Given this list of marker genes Cdc27, Sox9, Pdia4, Zfp422, Igf1r, here is a description of the gene set: Early prostate development genes (up-regulated at 6 hr dihydrotestosterone) which are also up-regulated in lower grade vs higher grade locally invasive prostate cancers. Mouse Gene Set: SCHAEFFER_PROSTATE_DEVELOPMENT_AND_CANCER_BOX3 from publication Schaeffer EM, Marchionni L, Huang Z, Simons B, Blackman A, Yu W, Parmigiani G, Berman DM (PMID 18794802) studied in species Mus musculus Cancer cells differentiate along specific lineages that largely determine their clinical and biologic behavior. Distinct cancer phenotypes from different cells and organs likely result from unique gene expression repertoires established in the embryo and maintained after malignant transformation. We used comprehensive gene expression analysis to examine this concept in the prostate, an organ with a tractable developmental program and a high propensity for cancer. We focused on gene expression in the murine prostate rudiment at three time points during the first 48 h of exposure to androgen, which initiates proliferation and invasion of prostate epithelial buds into surrounding urogenital sinus mesenchyme. Here, we show that androgen exposure regulates genes previously implicated in prostate carcinogenesis comprising pathways for the phosphatase and tensin homolog (PTEN), fibroblast growth factor (FGF)/mitogen-activated protein kinase (MAPK), and Wnt signaling along with cellular programs regulating such 'hallmarks' of cancer as angiogenesis, apoptosis, migration and proliferation. We found statistically significant evidence for novel androgen-induced gene regulation events that establish and/or maintain prostate cell fate. These include modulation of gene expression through microRNAs, expression of specific transcription factors, and regulation of their predicted targets. By querying public gene expression databases from other tissues, we found that rather than generally characterizing androgen exposure or epithelial budding, the early prostate development program more closely resembles the program for human prostate cancer. Most importantly, early androgen-regulated genes and functional themes associated with prostate development were highly enriched in contrasts between increasingly lethal forms of prostate cancer, confirming a 'reactivation' of embryonic pathways for proliferation and invasion in prostate cancer progression. Among the genes with the most significant links to the development and cancer, we highlight coordinate induction of the transcription factor Sox9 and suppression of the proapoptotic phospholipid-binding protein Annexin A1 that link early prostate development to early prostate carcinogenesis. These results credential early prostate development as a reliable and valid model system for the investigation of genes and pathways that drive prostate cancer.